The following is a description of a gene set: from publication Eppert K, Takenaka K, Lechman ER, Waldron L, Nilsson B, van Galen P, Metzeler KH, Poeppl A, Ling V, Beyene J, Canty AJ, Danska JS, Bohlander SK, Buske C, Minden MD, Golub TR, Jurisica I, Ebert BL, Dick JE (PMID 21873988) Human Gene Set: EPPERT_HSC_R Genes up-regulated in human hematopoietic stem cell (HSC) enriched populations compared to committed progenitors and mature cells. Xenograft studies indicate that some solid tumors and leukemias are organized as cellular hierarchies sustained by cancer stem cells (CSCs). Despite the promise of the CSC model, its relevance in humans remains uncertain. Here we show that acute myeloid leukemia (AML) follows a CSC model on the basis of sorting multiple populations from each of 16 primary human AML samples and identifying which contain leukemia stem cells (LSCs) using a sensitive xenograft assay. Analysis of gene expression from all functionally validated populations yielded an LSC-specific signature. Similarly, a hematopoietic stem cell (HSC) gene signature was established. Bioinformatic analysis identified a core transcriptional program shared by LSCs and HSCs, revealing the molecular machinery underlying stemness properties. Both stem cell programs were highly significant independent predictors of patient survival and were found in existing prognostic signatures. Thus, determinants of stemness influence the clinical outcome of AML, establishing that LSCs are clinically relevant and not artifacts of xenotransplantation. studied in species Homo sapiens, and this is the list of marker genes: ADGRG6, HES1, RCSD1, KLF4, RGCC, MECOM, HSP90B1, CFH, BEX1, DAPK1, KAT6A, HOXB3, RLIM (ring finger protein, LIM domain interacting), TPT1, FNBP1, H2BC6, PNP, H2BC8, H2AC18, RNF125, SPINK2, FRMD4B, HLA-DRB4, ERG, MSI2, EPC1, MSMO1, FAM169A, RBM7, ZNF165, GCNT2, NPR3, CRIM1, MLLT3, HOPX, ITSN2, KSR1, TMEM200A (transmembrane protein 200A), ZBTB4, PLSCR4, SLC25A36, H2BC5, CALN1, FOXO1, OSER1, PROM1, PAN3-AS1, ST3GAL6, C2orf69, DRAM1 (NCBI Gene Id 55332), DDX5, FGD5 (NCBI Gene Id 152273), LPP, ABCB1, BCL11A, MREG, ABTB3, PPP1R16B, ZDHHC21, RSL1D1, DUSP6, FAM106A, TFPI, CD109, ASXL1, HTR1F, JUN, ELK3, KMT2A, SMARCA1, RUNX2, TCF12, OGT, SOCS2, ATP8B4, TMEM107, MEIS1, BAALC, GNL1, PTK2, HLF, EIF5, CRHBP, DLK1, FLT3, INSIG1, DACH1, PCNX1, FAM30A, ANK3, RBPMS, RPS20P22, SMARCA2, MAFK, MCTP1, WDR91, MYO5C, PDE10A, KDM2A, CACNB2, CYLD, HOXB2, KBTBD8, GUCY1A1, ZEB1, SLC17A9, DST, PNISR, ENSG00000275616, TCEAL9, HOXA5, RPL31, H2BC10, YES1, TMEM38B, LONP2, DNAJB9, ALCAM, PAM, IPO11, RIMKLB, INPP4B, SPTBN1, COL5A1, SEL1L3, FAM3C, PRKCH (NCBI Gene Id 79030)